Given this list of marker genes Ift70a1, Ift27, Ift56, Ift57, Ift46 (intraflagellar transport 46), Ift81, Ift172 (NCBI Gene Id 67661, intraflagellar transport 172), Ift20, Ubxn10, Ift80, Trim59, Traf3ip1, Rabl2, Ift22, Cluap1, Ift74, Ift70b, Ift88, Ift70a2, Ift25, Ift52, here is a description of the gene set: The larger subcomplex of the intraciliary transport particle; characterized complexes have molecular weights around 550 kDa. Mouse Gene Set: GOCC_INTRACILIARY_TRANSPORT_PARTICLE_B studied in species Mus musculus